The following is a description of a gene set: Mouse Gene Set: GOMF_G_PROTEIN_BETA_GAMMA_SUBUNIT_COMPLEX_BINDING Binding to a complex of G-protein beta/gamma subunits. species: Mus musculus, and this is the list of marker genes: Gnai3, Gna14, Cetn1, Gnat2, Gnaq, Gna11, Gnao1, Adora1, Gnas, Gnal, Adcy2, Cetn2, Gnat3, Pik3r5, Cetn3, Gna13, Gna15, Gna12, Plcb2, Gnaz, Gnat1, Gnai1, Cetn4, Gnai2, Adcy4